Given this list of marker genes PAICS, IMPDH2 (inosine monophosphate dehydrogenase 2), GART, ATIC, DLG1, TJP2, ADSL, PRTFDC1, ADK, MAGI3, IMPDH1, CARD11, GMPS, DLG2, LRGUK, GDA, NT5C2, GUK1, APRT, PPAT, GMPR2, ADA, AMPD1, PFAS, CASK (calcium/calmodulin dependent serine protein kinase), MPP1, HPRT1, XDH, here is a description of the gene set: Human Gene Set: GOBP_GMP_METABOLIC_PROCESS The chemical reactions and pathways involving GMP, guanosine monophosphate. studied in species Homo sapiens